Given this list of marker genes STK38, PDCD4 (programmed cell death 4), TLR6, AGT, CRIPTO, PDGFB, MAP3K4, TPD52L1, SASH1, TRIB3, MAP3K10, DIRAS2, FLT3 (NCBI Gene Id 2322), DUSP1, CDK12, APOE (NCBI Gene Id 99), S100A12, DNAJA1, MAP4K2, SERPINB3, NPPA, DRD4, MAPK8IP1, PIK3CG, PTPN1, ARHGEF5, ERN1, PIK3R6, PDGFRB, FGFR1, DUSP7, SNF8, ADIPOQ, PTPN22, PTPRJ, TRIB1, MST1R, TSG101, TENM1, HIPK3, KSR1, RGS14, FGF16, PAQR3, DIRAS1, FLT1, ELANE, FGF2, RASGRP1, TNF, TAOK3, TRAF2, HGS, ERBB2 (NCBI Gene Id 2064), TRAF6, TRIB2, CD300A (NCBI Gene Id 11314), MAP3K7, PDCD10, NEK10, DEFB114, AIDA, LYN, MAP3K11, CDK5RAP3, MAP3K5, FGF1, EZH2, PIK3R5, FGF18, here is a description of the gene set: Any process that modulates the frequency, rate or extent of MAP kinase activity. species: Homo sapiens Human Gene Set: GOBP_REGULATION_OF_MAP_KINASE_ACTIVITY